Given this list of marker genes NDRG1, CSTB, ELF3, MMP12, MT3, TUBGCP4, CD63, PSPH, LY6D, NT5E, AKR1B1, KRT8, CYP39A1, PPL (periplakin), ACTG1, PSRC1, RALB, MGMT, IGFBP6, GIPC2, LY6E, ATP5IF1, MTHFD2, LCN2, VIL1, RAD51B, CNN1, MFGE8, USP18, IGFBP1, SLC13A3, SERPINA6, TLR1 (NCBI Gene Id 7887), MT2A, ICAM1, IGF2, PLSCR1, PLAT, SLC1A4, CBR1, NEDD9, RACK1, SLPI, CSN3, BTG2, ANXA2, GSTM2, UAP1L1, TAGLN2, RPS24, APP, LPL, HTATIP2, GSTM1, TFRC, BTG3, RAB3D, RPL12, ETS2, TFF3, CCND1, here is a description of the gene set: Genes up-regulated in hepatocellular carcinoma (HCC) tissue of MYC and TGFA double transgenic mice. species: Homo sapiens Genetically modified mice have been extensively used for analyzing the molecular events that occur during tumor development. In many, if not all, cases, however, it is uncertain to what extent the mouse models reproduce features observed in the corresponding human conditions. This is due largely to lack of precise methods for direct and comprehensive comparison at the molecular level of the mouse and human tumors. Here we use global gene expression patterns of 68 hepatocellular carcinomas (HCCs) from seven different mouse models and 91 human HCCs from predefined subclasses to obtain direct comparison of the molecular features of mouse and human HCCs. Gene expression patterns in HCCs from Myc, E2f1 and Myc E2f1 transgenic mice were most similar to those of the better survival group of human HCCs, whereas the expression patterns in HCCs from Myc Tgfa transgenic mice and in diethylnitrosamine-induced mouse HCCs were most similar to those of the poorer survival group of human HCCs. Gene expression patterns in HCCs from Acox1(-/-) mice and in ciprofibrate-induced HCCs were least similar to those observed in human HCCs. We conclude that our approach can effectively identify appropriate mouse models to study human cancers. from publication Lee JS, Chu IS, Mikaelyan A, Calvisi DF, Heo J, Reddy JK, Thorgeirsson SS (PMID 15565109) Human Gene Set: LEE_LIVER_CANCER_MYC_TGFA_UP